Given this list of marker genes Cib1, Zfp385a, Mef2c, Wdr1, Tubb1, Mpig6b, Tpm4, Mpl, Zfpm1 (NCBI Gene Id 22761), Ptpn11, Bap1, Ptprj, Ep300, Gata1, Actn1, Ptpn6, Vps33a, Prkdc, Nbeal2, Srf, Myh9, Mfap2, C1galt1c1, Tal1, Csf1r, Clec1b, here is a description of the gene set: Mouse Gene Set: GOBP_PLATELET_MORPHOGENESIS species: Mus musculus Generation and organization of a platelet, a non-nucleated disk-shaped cell formed by extrusion from megakaryocytes, found in the blood of all mammals, and mainly involved in blood coagulation.